Given this list of marker genes Commd1, Mark1, Cidea, Gsdmd, Nrgn, Atp13a2, Uqcc3, Plekhn1, Sestd1, Deptor, Pltp, Pitpnc1, Pitpnm1, Rapgef2, Opa1, Smpd3, Jph2, Rapgef6, Gramd1b, Micall1, Cidec, Cideb, Pacsin2, Mapkap1 (mitogen-activated protein kinase associated protein 1), here is a description of the gene set: studied in species Mus musculus Mouse Gene Set: GOMF_PHOSPHATIDIC_ACID_BINDING Binding to phosphatidic acid, any of a class of glycerol phosphate in which both the remaining hydroxyl groups of the glycerol moiety are esterified with fatty acids.